Given this list of marker genes HGS, VPS36, VPS4B, CHMP6, TOM1L1, STAM, HDAC6, CHMP3, VPS37A, RNF126 (ring finger protein 126), SNF8, VPS28, PLAA, VPS37B, UBAP1L, CHMP2A, STAM2 (signal transducing adaptor molecule 2), VPS4A, NEDD4, UBAP1, VPS37C, CHMP2B, CHMP1B, CHMP7, CHMP4A, VPS25, PTPN23, CHMP4BP1 (NCBI Gene Id 100420498), VPS37D, CHMP4C, MVB12B, TSG101, CHMP1A, CHMP5, MVB12A, CHMP4B, RNF115, here is a description of the gene set: Human Gene Set: GOBP_UBIQUITIN_DEPENDENT_PROTEIN_CATABOLIC_PROCESS_VIA_THE_MULTIVESICULAR_BODY_SORTING_PATHWAY The chemical reactions and pathways resulting in the breakdown of a protein or peptide covalently tagged with ubiquitin, via the multivesicular body (MVB) sorting pathway; ubiquitin-tagged proteins are sorted into MVBs, and delivered to a lysosome/vacuole for degradation. studied in species Homo sapiens